Given this list of marker genes Dcun1d5, Epas1, Dcun1d3, Cdkn2a, Dcun1d1, Rpl5, Dcun1d4, Cops9, Tes3-ps, Hif1a, Dcun1d2, Rpl11, here is a description of the gene set: Any process that modulates the frequency, rate or extent of protein neddylation. Mouse Gene Set: GOBP_REGULATION_OF_PROTEIN_NEDDYLATION species: Mus musculus